The following is a description of a gene set: Human Gene Set: FREDERICK_PRKCI_TARGETS Protein kinase Ciota (PKCiota) drives transformed growth of non-small cell lung cancer (NSCLC) cells through the Rho family GTPase Rac1. We show here that PKCiota activates Rac1 in NSCLC cells by formation of a PKCiota-Par6alpha complex that drives anchorage-independent growth and invasion through activation of matrix metalloproteinase-10 (MMP-10) expression. RNAi-mediated knockdown of PKCiota, Par6alpha or Rac1 expression inhibits NSCLC transformation and MMP-10 expression in vitro. Expression of wild-type Par6alpha in Par6alpha-deficient cells restores transformation and MMP-10 expression, whereas expression of Par6alpha mutants that either cannot bind PKCiota (Par6alpha-K19A) or couple to Rac1 (Par6alpha-DeltaCRIB) do not. Knockdown of MMP-10 expression blocks anchorage-independent growth and invasion of NSCLC cells and addition of catalytically active MMP-10 to PKCiota- or Par6alpha-deficient cells restores anchorage-independent growth and invasion. Dominant-negative PKCiota inhibits tumorigenicity and MMP-10 expression in subcutaneous NSCLC tumors. MMP-10 and PKCiota are coordinately overexpressed in primary NSCLC tumors, and tumor MMP-10 expression predicts poor survival in NSCLC patients. Our data define a PKCiota-Par6alpha-Rac1 signaling axis that drives anchorage-independent growth and invasion of NSCLC cells through induction of MMP-10 expression. Genes down-regulated in H1703 cells (non-small cell lung cancer, NSCLC) after knockdown of PRKCI by RNAi. species: Homo sapiens from publication Frederick LA, Matthews JA, Jamieson L, Justilien V, Thompson EA, Radisky DC, Fields AP (PMID 18427549), and this is the list of marker genes: ALDH1A1, KRTAP26-1, SMC1B, OR2H1, POGLUT3 (protein O-glucosyltransferase 3), KYNU, STC1, MMP10, PHLDB2, PRKCI